Given this list of marker genes NF2, GLIPR1, BLMH, FOS, GSS, BAX, RHBDF1, KLK3, TMEM11, MYC, FPR2, RBMS1, USP22, PAXIP1, GPAA1, PCF11, AP1B1, CADM4, BRD2, C1QL1, USP9X, KRT7, CYP2A13, EIF2AK2, here is a description of the gene set: A major challenge for kidney transplantation is balancing the need for immunosuppression to prevent rejection, while minimizing drug-induced toxicities. We used DNA microarrays (HG-U95Av2 GeneChips, Affymetrix) to determine gene expression profiles for kidney biopsies and peripheral blood lymphocytes (PBLs) in transplant patients including normal donor kidneys, well-functioning transplants without rejection, kidneys undergoing acute rejection, and transplants with renal dysfunction without rejection. We developed a data analysis schema based on expression signal determination, class comparison and prediction, hierarchical clustering, statistical power analysis and real-time quantitative PCR validation. We identified distinct gene expression signatures for both biopsies and PBLs that correlated significantly with each of the different classes of transplant patients. This is the most complete report to date using commercial arrays to identify unique expression signatures in transplant biopsies distinguishing acute rejection, acute dysfunction without rejection and well-functioning transplants with no rejection history. We demonstrate for the first time the successful application of high density DNA chip analysis of PBL as a diagnostic tool for transplantation. The significance of these results, if validated in a multicenter prospective trial, would be the establishment of a metric based on gene expression signatures for monitoring the immune status and immunosuppression of transplanted patients. from publication Flechner SM, Kurian SM, Head SR, Sharp SM, Whisenant TC, Zhang J, Chismar JD, Horvath S, Mondala T, Gilmartin T, Cook DJ, Kay SA, Walker JR, Salomon DR (PMID 15307835) Genes down-regulated in kidney biopsies from patients with well functioning kidneys more than 1-year post transplant compared to the biopsies from normal living kidney donors. studied in species Homo sapiens Human Gene Set: FLECHNER_BIOPSY_KIDNEY_TRANSPLANT_OK_VS_DONOR_DN